Given this list of marker genes Kdm5c, Kdm5d, Kdm5a, Kdm1b, Kdm5b, Riox1, here is a description of the gene set: Mouse Gene Set: GOMF_HISTONE_H3K4ME_H3K4ME2_H3K4ME3_DEMETHYLASE_ACTIVITY Catalysis of the removal of a methyl group from a tri, a di or a monomethyl-lysine residue at position 4 of the histone H3 protein. This is a dioxygenase reaction that is dependent on Fe(II) and 2-oxoglutarate. studied in species Mus musculus